The following is a description of a gene set: from publication Chen Y, Wang X (PMID 31504780) Genes predicted to be targets of miRBase v22 microRNA hsa-miR-377-3p in miRDB v6.0 with MirTarget v4 prediction scores > 80 (high confidence targets). Human Gene Set: MIR377_3P species: Homo sapiens, and this is the list of marker genes: TMOD2, SRSF1, ZCCHC17, TMX1, ZZZ3, ZNF516, DNAJC6, MED13L, TM6SF1, RBMS1, TAPT1, SLC4A10, RIN2, IRX2, LMX1A (LIM homeobox transcription factor 1 alpha), FBXO33, TAF4, BCL2L1, POC1B-GALNT4, GRSF1, USP49, SESN1, RNF38, ATL2, CTSC, NT5E, INSC, CSRNP3, INO80D, B4GALT6, GXYLT2, UMAD1, SLC11A2, CCNT2, SLC6A8, STRN4, NTS, TUBE1, C5orf24, RFC1, CELF1, NLGN1, GREM2, ARL8B (ADP ribosylation factor like GTPase 8B), PLPPR5, IL18R1, KLF7, PEX14, CAMTA1, TMEM273, C21orf91, OCRL, CDC14A, CDKN1B, NAP1L1, KCTD2, GLS, RPS6KB1, C8orf44-SGK3, PCDH7, XIAP, VDAC3, MAT2B, SVIP, SETBP1, ZFP36L1, FLVCR1, TTLL7, STOX2, MAP1A, IDS, MCF2, CACNA2D1, ARID1A (NCBI Gene Id 8289), CCDC68, FBXO30 (NCBI Gene Id 84085), ARID4B, RALGPS2, TRIP12, PITX2, NEGR1, QKI, KRTAP19-3, ZBTB6, NRXN1, IPO5, GPR88, SGK3, MAP3K7, RSBN1, SLC4A7, FBXO32, LAMC1, SLC6A19, SNX16, LIN28B, XPO7, ENPP6, PSME4, UBE2H, RB1, USP13, CENPV, ARMC8, NRP2, OSBP2, MSR1, AGAP5, RBM33 (RNA binding motif protein 33), TMED2, CASK (calcium/calmodulin dependent serine protein kinase), HAPSTR1, GALNT4, NUFIP2, JAG1, PPM1A, ERGIC1, ULK1, DCP1A, FNBP1L, FLYWCH2, DDX31, SYT11, CUL1, NETO1, HTR7, IL1RN, PTPRB, OSBPL8, UBA3, CEP135, KIF13A, SOD2, RABGAP1L, STK35, XPOT, TASOR, HP1BP3, PPP3R1, NAA15, ETNK1, WASF1 (NCBI Gene Id 8936), SMIM3, CDV3, GRM6, AAK1, TRIO, DCAF12, NKRF, INPP5E, CLXN, MARCHF3, PTPRT, PCDH10, ANKRD42, RNMT, SPTLC1, CDH13, RASSF8, UNC80, PLCB1, ETS1, PCF11, DARS2, CRELD1, PAQR3 (progestin and adipoQ receptor family member 3), RBM18, UBE2D2, NCOA1, AGAP6, CD274, CFTR, ARHGAP5, KAT6A (NCBI Gene Id 7994), C2, SEPTIN2, EYA4, MGAM, IRX3, UBXN10, ZNF148, ARHGEF28, RNF182, HDAC2, CHUK, OTULIN (OTU deubiquitinase with linear linkage specificity), FZD6, CREBL2 (NCBI Gene Id 1389), C7orf57, OCLN, DNAJB1, NUP153 (NCBI Gene Id 9972), NT5C3B, CARTPT (CART prepropeptide), CNOT6, CCDC117, ALKAL1, TP63, SEMA6A, ILRUN, SCN8A, CAPZB, NXPH3, PHF6, MINAR1, FBXO4, EIF4ENIF1 (NCBI Gene Id 56478), XRCC4, CAND1, AGAP4, NELFA, BEND3, H3-3A, SLC39A10 (solute carrier family 39 member 10), GPATCH2L, CARF, STARD7, KLHL24 (kelch like family member 24), ATXN7, KCNMA1, NRF1, PPP1R9A, CDON, KCNA4, PUM2, HS3ST5, SGCB, DNAJB9, NR6A1, LRPAP1, LIG4, PDE10A, HMOX1, ABHD18, GBP1, PTGS1, GPCPD1, FOXJ3